The following is a description of a gene set: Top genes down-regulated in granulocyte/macrophage progenitors (GMP) upon expression of MLL-CBP fusion. Chromosomal translocations that fuse the mixed lineage leukemia (MLL) gene with multiple partners typify acute leukemias of infancy as well as therapy-related leukemias. We utilized a conditional knockin strategy to bypass the embryonic lethality caused by MLL-CBP expression and to assess the immediate effects of induced MLL-CBP expression on hematopoiesis. Within days of activating MLL-CBP, the fusion protein selectively expanded granulocyte/macrophage progenitors (GMP) and enhanced their self-renewal/proliferation. MLL-CBP altered the gene expression program of GMP, upregulating a subset of genes including Hox a9. Inhibition of Hox a9 expression by RNA interference demonstrated that MLL-CBP required Hox a9 for its enhanced cell expansion. Following exposure to sublethal gamma-irradiation or N-ethyl-N-nitrosourea (ENU), MLL-CBP mice developed myelomonocytic hyperplasia and progressed to fatal myeloproliferative disorders. These represented the spectrum of therapy-induced acute myelomonocytic leukemia/chronic myelomonocytic leukemia/myelodysplastic/myeloproliferative disorder similar to that seen in humans possessing the t(11;16). This model of MLL-CBP therapy-related myeloproliferative disease demonstrates the selectivity of this MLL fusion for GMP cells and its ability to initiate leukemogenesis in conjunction with cooperating mutations. from publication Wang J, Iwasaki H, Krivtsov A, Febbo PG, Thorner AR, Ernst P, Anastasiadou E, Kutok JL, Kogan SC, Zinkel SS, Fisher JK, Hess JL, Golub TR, Armstrong SA, Akashi K, Korsmeyer SJ (PMID 15635450) Human Gene Set: WANG_TARGETS_OF_MLL_CBP_FUSION_DN studied in species Mus musculus, and this is the list of marker genes: TMEM109, RIOX2, FABP5, DLAT, DEGS1, IRAK1, TSC22D1 (TSC22 domain family member 1), G6PD, PITRM1, PSMC5, CCDC86, NRP1, CCND2, NIPSNAP1 (nipsnap homolog 1), LACTB, DOCK8 (dedicator of cytokinesis 8), CTSZ, VDAC1, CAT, GGCT, AMOT, RIC8A, HARS1, PPIC, GABARAPL1, ALDH7A1, RASSF1, STRAP, TMED10, CUL4A, UXS1, CWC22 (CWC22 spliceosome associated protein homolog), TTC27, TRIAP1, GTPBP4, NMD3, FGF23, NAA10, SELENOW, CPOX, KPNB1, OSBPL1A, TOMM70 (NCBI Gene Id 9868), FTSJ3, GLRX3